Given this list of marker genes TPST2, FGA, TPST1, ANO6, GP1BA, GP5, F10, ADAMTS13, FGB, F9, APP, F11, F8, COL1A1, FGG, GP9, PROC, F2, PROS1, GP1BB, F5, COL1A2, VWF, GGCX, here is a description of the gene set: part of: Disease Reactome Pathway: Diseases of hemostasis Hemostasis is a complex process that leads to the formation of a blood clot at the site of vessel injury. Three phases can be distinguished: primary hemostasis or formation of a platelet plug, secondary hemostasis, or coagulation and fibrinolysis (Kriz N et al. 2009). Defects in hemostasis cause an imbalance between the coagulation and fibrinolytic systems and may lead either to hypercoagulation, which can result in thrombosis, or to hypocoagulation and increased susceptibility to bleeding (also known as hemorrhagic diathesis) (van Herrewegen F et al. 2012a,b; Kumar R & Carcao M 2013). Abnormalities can result from disorders of the platelets (primary hemostasis defect), coagulation factors defects (secondary hemostasis defect), or a combination of both (van Herrewegen F et al. 2012a,b; Kumar R & Carcao M 2013). Coagulation disorders may be inherited or acquired. The module also describes an abnormal FXII- mediated activation of the pro-inflammatory kallikrein‐kinin system (KKS) that leads to an excessive formation of bradykinin causing increased vascular permeability at the level of the post capillary venule and results in hereditary angioedema (HAE). studied in species Homo sapiens